Given this list of marker genes RIMBP2, CCNB1, TGFBR1, LHX8, MED13L, DMTF1, SIN3B, USP18, EXOC6B, ATXN1, RAB22A, GLRA2, FLRT2, G2E3, CDYL2, MOSMO, OGA, SLF2, VPS26A, GSTT2B, GRK3, BNIP2, OTUD4, OCRL (NCBI Gene Id 4952), USP9X, TNFAIP1, RAB21, KLHL2, SMAD3, SMOC2, RAB27B, TECRL, SLC35A5, DPH6, MSANTD4, KLHL29, CDH6, GFI1, ZNF837, TYW5, LRRC31, CARNMT1, SERINC1, FBXL3, PFN2, CCP110, ANXA4, SAMTOR, SH3PXD2A, IRAK4, ABCA1, HECTD2, DPYSL5, PLEKHA6, TLR5 (NCBI Gene Id 95519), FAM83B, PTPN13 (protein tyrosine phosphatase non-receptor type 13), MXI1, HIF1A, SEPTIN8, EIF2S1, DEPTOR, PCDH19, RNF145, SATB2, ZBTB6, KCTD18, TOX3, ARAP2, GNS (glucosamine (N-acetyl)-6-sulfatase), POLR3E, RGPD6 (RANBP2 like and GRIP domain containing 6), ITPRIPL2, KIRREL1, TBC1D9, MSL2, FURIN, MKNK1, ANLN (NCBI Gene Id 54443), ARL4C, MAP3K9, NOX4, SORCS1, RALGAPB, PLCB1, SPACA1, EIF4G2, ZFP91, NECTIN2, CPSF6, PCDH7, PDE4A, G3BP1, SINHCAF, DIDO1, SEMA5A, CPEB3, DIPK2A, ITCH, SUMF1, RND3, MAP6, UXS1, ENTPD4, AMZ1, ARID4B, PRICKLE2, MAN1A1, EVA1A, NPAS3, BTAF1, KRTAP4-9, ADAMTS5, ZNF334, TBC1D15 (TBC1 domain family member 15), FXN, ABHD2, GIMAP4, RTCA, AHCTF1, SALL1, PDF, EHD3, GBF1 (golgi brefeldin A resistant guanine nucleotide exchange factor 1), GOLIM4, ZNF362, LIN28B, SPTY2D1, PRKAR2A, PLEKHA8, VLDLR, DCP1A, MOSPD1, RRAGD, CYP20A1, PLEKHM3, AFG1L, CHUK, RNF216, ZNF320, RFX4, LUC7L3, PIAS2, POMC, DCBLD2, TNKS1BP1, TXNIP, AKAP11, PPP6R2, JAZF1, PRCP, UNKL, CREBRF, APEX1, TBKBP1, BCOR, KPNA1, TAGAP, COG8 (component of oligomeric golgi complex 8), GRIN2C, KRT81, CSF1, EIF4G3, KCNJ13, RHOV, RGPD8, ADAM22, LIMK1, CDKN1A, SLC31A1, CERS5, MYO3A, PKN2, HAPSTR1, NR2C2, SLC44A4 (NCBI Gene Id 87892), RIMKLB, TRPC5, XKR9, ABI1, RGPD5, GJA1, EPHA5, CLEC2D, RAPGEFL1, NPEPL1, RBSN, ELK4, PXYLP1, KIF26B, ATP2B1, TNRC6A, HNRNPM, E2F1, TAFA1, SSR1, CKS1B, TRIM13, NUFIP2, RAB11B, AAK1, MYCN, HIPK3, ABL2, PHF14, NDFIP1, ROCK2, PLAGL2, NEDD4L, here is a description of the gene set: from publication Chen Y, Wang X (PMID 31504780) Human Gene Set: MIR520G_3P_MIR520H Genes predicted to be targets of miRBase v22 microRNA hsa-miR-520g-3p, hsa-miR-520h in miRDB v6.0 with MirTarget v4 prediction scores > 80 (high confidence targets). species: Homo sapiens